Given this list of marker genes TARBP2, MIR23B, RAN, BCDIN3D, POLR2I, POLR2C, DGCR8, POLR2K, POLR2A, POLR2F, POLR2D, AGO2, DROSHA, AGO4, AGO1, POLR2J, DICER1, POLR2G, POLR2H, PRKRA, XPO5, POLR2B, POLR2L, AGO3, POLR2E, here is a description of the gene set: MicroRNA (miRNA) biogenesis Human Gene Set: REACTOME_MICRORNA_MIRNA_BIOGENESIS studied in species Homo sapiens